Given this list of marker genes ITPR1, ATP2A3, ITPR3, IRAG1, EHD1, DMTN, SERPINA5, F2R, ATP2A2, ATP2A1, ITPR2, here is a description of the gene set: Human Gene Set: GOCC_PLATELET_DENSE_TUBULAR_NETWORK A network of membrane-bounded compartments found in blood platelets, where they regulate platelet activation by sequestering or releasing calcium. The dense tubular network exists as thin elongated membranes in resting platelets, and undergoes a major ultrastructural change, to a rounded vesicular form, upon addition of thrombin. species: Homo sapiens